Given this list of marker genes Med18, Lnx1, Zbtb45, Cacng2, Mlxip, Polrmt, Smg7, Ino80d, Cdc16, Slc39a3, Adnp, Glra1 (glycine receptor, alpha 1 subunit), Inpp5f, Piezo1, Zmpste24, Pgk1, Ino80dos, Mbtps2, Scrt1, Gtf3c6, here is a description of the gene set: from publication Yevshin I, Sharipov R, Kolmykov S, Kondrakhin Y, Kolpakov F (PMID 30445619) species: Mus musculus Mouse Gene Set: ZFP981_TARGET_GENES